Given this list of marker genes LYPD4, SGSM3, METTL5, DMBX1 (NCBI Gene Id 127343), GNAI2, RCC2, PRDX3, GGA2, SPNS3, GRP, MFGE8, HNRNPD, PMF1, AHDC1, SH3BP2, FZD6, CAMK1, COX5A, DOCK1, ADAMTS1, BCR, PAM, MAGOHB, RERG, BBS7, SKA2, GCLM, EXOSC9 (NCBI Gene Id 5393), SNX9, TTPA, RILPL1, PRKG1, CIT, CHAF1B (chromatin assembly factor 1 subunit B), GMDS, STAT5A, GPR179, ESCO2, WWC1, EIF2A (eukaryotic translation initiation factor 2A), BTF3, RILPL2, MPHOSPH6, CXXC4, SLC14A1, HK2 (hexokinase 2), NELFE, SULT6B1, RNF217, KDM2B, BAG6, KAT7, MID1IP1, SERINC3, TCP1, NECTIN2, KPNA3, SEMA3D, MSMB, PEX19, YARS2, NPTX1, HAAO, CTHRC1, MTHFD1L, B9D1, ZEB2, VBP1, ALDOC, FXN, CCL4, AGTR1 (angiotensin II receptor type 1), RNF149, CDH10, FAM111A, H2AZ1, SLC35B2, GNL3, GLIPR1, DNAJC6, NDC1, ECI2, ORC6, DKKL1, TSPAN7, SCNN1A, TERF2, COL5A3, MSRB2, DNAL1, NSG1, NTRK2, BTC (NCBI Gene Id 685), SYNGR1, AGBL3, KRT84, FOXRED2, CA9, DEPP1, CHST11, RNASE1, TRIP10 (thyroid hormone receptor interactor 10), MCFD2, FADS1, LMF1, POC1B, HOXA3, TMEM119, CDC45, THOP1, SPEN, APIP, PCDHB7, MXI1, NHP2, CUL1, GALNT14, CIMAP1B, SNX7, GCSH, ANAPC2, MYCT1, MAGED1, ITFG2 (integrin alpha FG-GAP repeat containing 2), FBXO3, ACOD1, CTSF, ELL, TMEM41A, PAICS, LAMC1, SERTAD2, TNFAIP8, FBXW4 (NCBI Gene Id 6468), ODF2L, AK4, NSD2, GPR150, SPAG1, PRKCD, TMBIM1, HDGF, FZD7, WASF1, KTI12, HSPD1, GARIN1B, SASH1, CAPZA3, C9, DTNBP1, RFC5, UNK, MZT2B, TIAM2, PTMS, GAPDH, RSPH3, PRIM2, IL3RA, CAMKK2, E2F6, RNF220, ELAVL1, BTBD3, AIFM2, PLEKHG3, TM6SF1 (NCBI Gene Id 53346), FIRRE, BRI3BP, GRIA2, IL11RA, HSD17B11, CELA2A, ARHGAP21, SLC18A1, KIF18A, PHF10, KCNB1 (potassium voltage-gated channel subfamily B member 1), KISS1R, TUBA3C, RAC3, PCDH15, KIF13A, PDAP1, UBQLN3, KRT26, FHL1, TRIM44, CHAD, SMIM3 (small integral membrane protein 3), RUVBL1, SMPD4, ASAH2, EGLN3, LCE2B, CDKN1A (cyclin dependent kinase inhibitor 1A), EME1, HNRNPAB, SLC48A1, here is a description of the gene set: Transcriptional response of murine allogeneic T cells (B10.BR) after stimulation with different organ-derived (spleen, liver, peripheral and mesenteric lymph nodes) dendritic cells (C57BL/6) in vitro studied in species Homo sapiens Genes up-regulated in allogeneic T cells after stimulation with dendritic cells from: peripheral lymph nodes (mLN) versus spleen. from publication Kim TD, Terwey TH, Zakrzewski JL, Suh D, Kochman AA, Chen ME, King CG, Borsotti C, Grubin J, Smith OM, Heller G, Liu C, Murphy GF, Alpdogan O, van den Brink MR (PMID 18178870) Human Gene Set: GSE5503_PLN_DC_VS_SPLEEN_DC_ACTIVATED_ALLOGENIC_TCELL_UP